Given this list of marker genes MAPK8, DYNLL1, BCL2L11, here is a description of the gene set: BIM acts as a sentinel to check the integrity of the cytoskeleton. It exists as two variant proteins: BIM-EL and BIM-L. In healthy cells, these two isoforms are sequestered to the dynein motor complex on microtubules via the dynein light chain DLC1. JNK or MAPK8 releases BIM in response to UV irradiation by phosphorylation. Reactome Pathway: Activation of BIM and translocation to mitochondria species: Homo sapiens part of: Activation of BH3-only proteins